The following is a description of a gene set: studied in species Homo sapiens Human Gene Set: KEGG_MEDICUS_REFERENCE_BMP_HAMP_SIGNALING_PATHWAY_AUXILIARY_FACTOR Pathway Definition from KEGG: (HJV,HFE,TFR2) -> ((ACVR2B,BMPR2)+(ACVR1,BMPR1A)) BMP-HAMP signaling pathway, auxiliary factor. Pathway ID: N01461. Pathway type: Reference. Pathway class: nt06507 TGFB signaling., and this is the list of marker genes: ACVR2B, HJV, ACVR1, BMPR1A (bone morphogenetic protein receptor type 1A), HFE, TFR2, BMPR2